Given this list of marker genes COLGALT1, COL4A1, NOTCH3, NAGA, PIK3C2A, HTRA1, here is a description of the gene set: A stroke related to a small infarct (2-20 mm in diameter) in the deep cerebral white matter, basal ganglia, or pons, that is presumed to result from the occlusion of a single small perforating artery supplying the subcortical areas of the brain. Lacunar stroke species: Homo sapiens Human Gene Set: HP_LACUNAR_STROKE